Given this list of marker genes MS4A2, GLRA3, CLCN2, GABRE, CHRNA7, CHRNB1, GRIK2, CLIC2, KCNB2, FXYD1, ASIC1, KCNH2, GABRA2, GJB1, GLRA1, CACNB4, GABRP, GABRD, P2RX3, HTR3A, GRIA3, P2RX1, CHRNE, SHROOM2, CLCNKB, GABRA1, RYR2, MLC1, FXYD7, SLC14A2, TPTE, KCNC3, GABRB3, CHRNA2, AQP9, GLRA2, GRIK1, KCNJ3, KCNJ11, AQP4, RYR1, KCNMB1, SCN1B, GJB5, KCNAB2, CLCNKA, GABRA6, KCNA6, KCNJ12, SLC9A5, KCNK1, CNGA3, KCNJ4, CHRNB4, GJC2, KCNE1, KCNJ2, CHRNA4, CLCN6, GRIK3, GRIN1, GABRR1, GABRA5, GABRG2, KCNA1, CHRNB3, KCNJ6, FXYD2, KCNK5, CACNG1, here is a description of the gene set: species: Homo sapiens Ion channels. Human Gene Set: MODULE_316